The following is a description of a gene set: species: Homo sapiens Human Gene Set: MODULE_183 RNA splicing., and this is the list of marker genes: RNMT, ADAR, KHSRP, IGF2BP3, SRSF7, SRSF3, HNRNPR, GRSF1, PABPC4, SNRPB2, CHERP, SNRPD1, HNRNPA1, DDX23, ZNF638, SLU7, THOC1, CELF2, PRP4K, SRSF1, SRSF9, SNRPG, DUSP11, PPP1R8, DDX17, TRA2B, SRSF10, HNRNPF, RBM4, SRSF6, DDX1, SNRPF, HNRNPUL1, HNRNPDL, HNRNPA2B1, HNRNPA0, HNRNPU, SRSF11, PABPC1, SLBP, PCBP1, SNRPD3, DHX8, LSM1, HNRNPC, PRPF8, U2AF1, RBM5, SSB (NCBI Gene Id 6741), SNRPC, SF3A3, SRPK2, SART3, PCBP2, RBM3, SNRPA1, KHDRBS1, SPOP, SFPQ, SF3A1, SRSF2, SNRPD2, HNRNPH1 (heterogeneous nuclear ribonucleoprotein H1), SNRPE, CSTF3